The following is a description of a gene set: Genes up-regulated in epithelial cells (24h): untreated versus interferon alpha. Type I and type II interferons (IFNs) bind to different cell surface receptors but activate overlapping signal transduction pathways. We examined the effects of a type I IFN (IFN-acon1) and a type II iFN (IFN-g1b) on gene experession in A549 cells and demonstrate that there is a common set of genes modulated by both IFNs as well as a set of gene specifically regulated by each, reflecting the activation of different signaling pathways. In particualr, IFN-g induced many more genes of the signaling pathways, apoptosis, and cytokine interactions than did IFN-a. Even with genes induced by both IFNs there were distinctive quantitativive differences in expression. IFN-g1b plays a major role in the induction and regulation of the complement pathway. Previous work has shown a synergistic antivral and antiproliferative effect of type I and type II IFNs in cell culture and in the treament of tumors in mice. We demonstrate that a majority of genes showed and additive effect of IFN-acon1 and IFN-g1b, but a subset of gene is synergistically induced; these incluce ISG10, MX2, OAS2, and other genes known to be involved in the antiviral response, TRAIL (TNFSF10) and caspases involved in apoptosis and chemokine genes RANTES, CXCL10, and CXCL11. Greater than additive transcription of some of these genes in the presence of both IFNs was confirmed by real-time kinetic RT-PCR. Elevated induction of many of these genes may be sufficient to explain the synergistic antiviral and antitumor effects of this combination of IFNS in vivo. Human Gene Set: GSE5542_UNTREATED_VS_IFNA_TREATED_EPITHELIAL_CELLS_24H_UP studied in species Homo sapiens from publication Sanda C, Weitzel P, Tsukahara T, Schaley J, Edenberg HJ, Stephens MA, McClintick JN, Blatt LM, Li L, Brodsky L, Taylor MW (PMID 16800785), and this is the list of marker genes: TRIM62, FMNL1, JOSD1 (NCBI Gene Id 9929), FTH1, RXRA, PAH, TNIP3, RNF19A, HIP1, ADAM8, TTC22, MYH9, SH2B3, FYCO1, SYTL3, ADCY9, ARHGAP35, GNB1, PCNX3, UEVLD, GALM (galactose mutarotase), ARHGAP10, PHACTR2, SLCO3A1, SLFN11, CTNNA1, RIPK3, MVD, SPN, PPP3CA, TP53INP1, PNPLA6, CCDC92, GATA3, SLFN12L, SH2D2A, NKG7, IDI1, FOSL2, YWHAH, SIK2, DVL3, KATNAL1, SHKBP1, PHF12, ABR, NABP1, TBXAS1, NCKAP1, FSHB, GRAMD4, BMPR1A, FCHO2, MBD2, APOBEC3G, OTOA, KSR1, RUNX3, ARAP2, ZNF532, FAS, GFPT2, CEP128, NF1, PPP4R1, PEA15, CHST11, P4HA2, ST3GAL4, CACNB3, SH3BP2, REEP5, CAMK2N1, DUSP10, PDE4B, PMAIP1, MRPL10, ST8SIA1, ZDHHC7, PPP4C, SNX33, EZR, CCRL2, MXD4, GLIPR2, AIM2, OSTF1, SIK3, ZNF821, ATP2A3, ANXA5, TOX, FAM199X, GNAO1, SFXN3, MICAL2, EMB, GIT2, CBFA2T2, RASAL3, CD99, SNX24, HNRNPUL1, ATOSB, RHBDF2, DUSP2, SLC6A6, ARHGDIA, MYO1F, LRP8, CDCA4, GTDC1, SEMA4A, PIAS3, ODF2L, PI4K2A, AKT1, LPIN2, RTL5, AHNAK, TIGIT, CAPN2 (calpain 2), PHTF1, NEDD9, GPR68, GPR19, RNF135, DPY19L1, AGFG2, NR3C1, MAPKAPK2, SPIRE1, ACOT9, ATP2B4, WDFY1, RNF166, OSBPL7, PTPRM, OGDH, GCNT1, MAN1A1, LIMK1, FYN, PHF2 (NCBI Gene Id 79448), NCOA7, ZNF335, STK40, LRIG1, GZMK, FNBP1, CFLAR, ALCAM (activated leukocyte cell adhesion molecule), CCDC167, PPP2R5C, YPEL3, CDK2AP1, TNFAIP3, TENT5C, ARF3, CALHM2, TRANK1, IDS, SLAMF1, ARHGEF12, GABARAPL1, TPTE2P6, DNAJC1, GFI1, CLSTN3, LRP10, PTPN9, EOMES, C1orf21, SUSD6, VXN, GAB3, HERPUD2, PIEZO1, CMIP, CLSTN1, STAT5B, ACADVL, ITPR3, F8, CACNB1, PRKCE, EPS15, C12orf75, SNRNP200, PLEKHA2, FLVCR2, ATXN1, RMDN3, RDX, SLFN13, NOD1, ANKRD27, RBMS3, DPP9, F2R